The following is a description of a gene set: studied in species Homo sapiens The transcription factor Foxp3 is usually considered the master regulator for the CD4+CD25+ from publication Hill JA, Feuerer M, Tash K, Haxhinasto S, Perez J, Melamed R, Mathis D, Benoist C (PMID 18024188) Genes up-regulated in comparsion of ActTreg versus ActCD4 (see Fig. 1 in the paper for details). Human Gene Set: GSE7460_TREG_VS_TCONV_ACT_UP, and this is the list of marker genes: ITGAE, NIBAN2, ATP11A, TNFRSF18, GPR15, EGR1, ALKBH6, UMAD1, ITGA6, PIAS3, PMEPA1, HMGN3, TMED3, MMAA, NCF4, TNFSF10, MIR22HG, PDCD1LG2, UBLCP1, ERBIN, STX11, POFUT1, IRAK1BP1, GEM, ICAM1, TRMO, LRRC57, IFTAP, IKZF2, GBP7, CTNNA1, FES, GBP2, TOX, GGH, RB1, GPBP1, TGFBR1, DDX5, SIPA1L2, TIAM1, NABP1, MYL9, PON3, APIP, CST11, RHOH, CLDND1, LMO7, TUBGCP4, MYO3B, TAB2, GBP4, UNC13D, MTERF1, SDC4, TANK, C6orf136, FAAP24, SLC35D1, SEC24A, REEP3 (NCBI Gene Id 221035), MXD1, RGS1, GOLM2, C1QTNF12, CEP162, GPHN, KLHL15, TAFA3, SLC9A5, C3orf80, DNAJA4, PPIG, CD38, ARMCX5, SLC15A3, CHORDC1, PROS1, SLC44A1, DUSP4, NT5E, ZFYVE16, SNX16, NCF1, NCMAP, LRRC61, OR4C3, PHIP, CNKSR3, CERS6, PHTF2, RUNX2, ACTA1, LYN, CDKL2, CD274, ZBTB18, LRIG1, NFKBIZ, NIPAL1, ESS2, CENPM, QNG1, WNT3, IFT80, UBE2L6, PRICKLE3, PPM1L, PLEKHA3, CIB1, IL33, MYB, KLHL2, ZNF474, ACOT9, PRDM2 (PR/SET domain 2), CHUK, TEAD1, ADAMTS6, GMCL1, GPR83, MAF, TRAPPC2, RABGAP1L, PIGX, TNFAIP3, CD69, SPSB1, MPRIP, DNAH7, ANKRD13C, PTAR1 (NCBI Gene Id 375743), CERK, GLIPR1L1, MYADM, PLAGL1, SFR1, STK32A (NCBI Gene Id 202374), SAR1B, ARHGAP20, CEP290, HIPK2, CDC73, LRRC8D, CPD, YOD1, SLC7A7, CSGALNACT2, SCIN, FAM174A, N4BP2, BCL2L1, STAT1, SKIL, STIM2, SGIP1, ATG10, DYNLL1, IKZF3, AKAP7, RANBP6, FHL2, TNFRSF4, SOWAHC, EFNA5, CALN1, CFTR, MSRB3, ARHGAP22, MCUB, ZFP36L1, COL1A2, RAB11FIP2 (NCBI Gene Id 22841), GOSR1 (NCBI Gene Id 9527), JADE1, FAM135A, FAM241A, SNAP23, ATL3, DUSP5, PLSCR1, SLC14A1, BECN1 (beclin 1), IFT70B, IKZF4, SUCO, FNBP1L, FOXP3, NDUFA4, KRAS, TUBB2B, CD48, SLC30A2, PPP1R3F, PCDH15, DIDO1, MARCHF5, CTLA4, FAIM